The following is a description of a gene set: Diseases of glycosylation Human Gene Set: REACTOME_DISEASES_OF_GLYCOSYLATION species: Homo sapiens, and this is the list of marker genes: MUC5AC, B3GLCT, GPC6, DPM3, ADAMTS13, ADAMTSL2, SPON1 (NCBI Gene Id 84806), ADAMTSL1, GALT, GPC3, MGAT2, B3GAT3, GNE, SBSPON, C1GALT1C1, ST3GAL3 (NCBI Gene Id 6487), NOTCH3 (notch receptor 3), MUC16, ALG9, B4GALT7, CSPG4, DPM2, B4GAT1, ADAMTSL5, ADAMTS1, SRD5A3 (steroid 5 alpha-reductase 3), MUC6, THSD7A (NCBI Gene Id 23249), DPM1, CHST14, MOGS, ADAMTS17, MUC5B, SDC1, EXT1, ALG2, THBS2, MUC20, DPAGT1, DAG1, MPDU1, ADAMTS3, MUC4, ADAMTS19, GALNT3, HSPG2, MUC13, BCAN, SSPOP, THSD1, MUC12, FMOD, MUC3A, GALE, SPON2, ADAMTS6, ADAMTSL4, MUCL1, MUC1, ALG12, ADAMTS16, SEMA5B, SDC4, PAPSS2, GLB1, MUC17, MUC7, CHST6, GPC5, PRELP, MUC21, LFNG, GALK1, CFP, SDC2, ADAMTS10, SLC26A2, ACAN, ADAMTS9, GPC1, ADAMTS15, ALG8, CSPG5, LARGE1, CHSY1, ADAMTS12, POMT2, MPI, PGM1, C1GALT1, OGN, LUM, ADAMTSL3, B4GALT1, NOTCH2, ADAMTS20, NCAN, CHST3, GALM, DCN, CTSA, POMGNT1 (NCBI Gene Id 55624), BGN, SDC3, NOTCH1, AGRN, NOTCH4, HEXA, ADAMTS5, RFT1, ALG13, ALG6, ADAMTS14, KERA, OMD, ADAMTS4, EXT2, DHDDS, ALG3, MUC15, ADAMTS7, HEXB, GFPT1, THSD7B, ALG14, NEU1, SEMA5A, ADAMTS18, ADAMTS2, GPC4, DOLK, THBS1, POMT1, B3GALT6, ADAMTS8, ALG11, GPC2, GALNT12, PMM2, THSD4, ALG1 (ALG1 chitobiosyldiphosphodolichol beta-mannosyltransferase), NUS1, VCAN, MAN1B1